The following is a description of a gene set: Genes up-regulated in activated CD4 T cells: wildtype versus over-expressing MIR17. miR-17 from the miR-17-92 cluster regulate activation-induced cell death in T cells and modulate inducible regulatory T cell differentiation. We used microarrays to detail the global program of gene expression modulated by miR-17 and aim to identify the potential targets of miR-17. from publication Jiang S, Li C, Olive V, Lykken E, Feng F, Sevilla J, Wan Y, He L, Li QJ (PMID 21972292) studied in species Homo sapiens Human Gene Set: GSE32533_WT_VS_MIR17_OVEREXPRESS_ACT_CD4_TCELL_UP, and this is the list of marker genes: NFKBID, TGIF1, BEND3, KTI12, TNFSF9, GLT8D2, NUFIP1 (NCBI Gene Id 26747), TMEM201, EXTL2, PRKRA, FXYD3, TOMM5, EMC8, TXLNG, NUDC, TRMT12, TMEM129, EPB41L4A, ZSCAN21, CDCA7L, STAU1, CUL5, CCDC59, PARGP1, TMEM70, SYT12, TMEM147, IGHA1, LAMP3, RAB21, MIX23, RPE, B3GNT5, RPS6KA3, MAIP1, RRP15, TRMT1, DDX18, NAXE, ENSG00000274253, ISOC2, TIMM17A, GPR171, TEAD4, UQCC6, FBXO30, BZW2, PSMD12, ARHGEF34P, FTSJ3, WDR75, REXO2, ZNF317, CRY1, CD24, MRPL36, MFSD12, FXN, ACAT1, ARFGEF2, VDR (NCBI Gene Id 7421), PARL, PAPOLA-DT, IPO7, GLUD1, PCCB, SUV39H2, SMC5 (NCBI Gene Id 23137), EIF3J, RPIA, CSF1 (NCBI Gene Id 1435), GTF2I, NCL, NOL10, CD226, TESK1, ETF1, POLR1B, OR51E1, NINJ1, GALNT2, CSNK2A1, EIF4A3, ZNF574, NUS1P3, CLNS1A, SACS, ABCC1, TNKS1BP1, NT5DC3, RPP25L, SLIRP, ORAI1, DYNLT3, TGFB3, NPIPB3, PWP2, PSMD13, ERCC3, CPSF4, UTP15, PIGZ, LINC01128, GAS7, KSR1, STRAP, RAB11FIP1, CCL1, RHOJ, AP3D1, PFAS, CNPY3, ILF3, CCDC6, NAF1, OPN3, XIRP1, SLC29A1, RAN, METAP2, DDX51, HSPA9, SRGAP2, POLR2K, IFT57, ZBTB21 (zinc finger and BTB domain containing 21), ANKLE2, HABP4, ELL2, CD81, RPS6KA1, SREBF1, MDM2, ENOSF1 (NCBI Gene Id 55556), SPAG1, METTL21A, AATF, IL10, RHOB, NIPA2, ACVR2B, MAPK4, KDM5B, TRAP1, RBM19, SRGAP2C, CDKN2D, DDX55, LMTK3, ARFGAP1, EPB41L4A-AS1, MRPL20, NCS1, SNRPC, IGF2R, POLR1G, GATA2, TSFM, GLRX3, TWNK, SEL1L, STAT5B, MRPL3 (NCBI Gene Id 11222), CCT4, RCAN1, ANKRD13B, DTD2, CNBP (CCHC-type zinc finger nucleic acid binding protein), TSEN2, PTEN, TDG, BATF3, G3BP1, PRR3, TMEM101, GPATCH4, WDR74, PHF6, UTP14A, KIAA0513, ENSG00000269210, XRN2, TRIM25, IL21R, GEMIN7, FABP5, FGL2, BCOR, CXXC5, CENPV, PIGW, LURAP1, DDX28, CMAHP, NOP58, DHRS11, AHCYL1, CD70, TNFSF14